The following is a description of a gene set: Mouse Gene Set: GOBP_MATERNAL_PLACENTA_DEVELOPMENT Maternally driven process whose specific outcome is the progression of the placenta over time, from its formation to the mature structure. The placenta is an organ of metabolic interchange between fetus and mother, partly of embryonic origin and partly of maternal origin. studied in species Mus musculus, and this is the list of marker genes: Dazap1, Ctsb, Tcf23, Ghsr, Bsg, Rxra (NCBI Gene Id 78740), Tppp3, Pla2g4a, Nr2f2, Ndrg3, Akt1, Cited2, Ndp, Ptn, Gja1, Prdm1, Rxrb, Prdx3, Tmed2, Mapk3, Stc2, Nodal, Parp1, Ptgis, Stc1, Kiss1, Ash1l (ASH1 like histone lysine methyltransferase), Ptgs2, Ppard, Stox2, Lif, Dedd, Cyp27b1, Gjb2, Ghrl, Ldoc1, Dcaf13, Bmpr2, Parp2, Il11ra1, Ctsl (cathepsin L), Mapk1, Junb, Cdh1, Vdr, Epor